The following is a description of a gene set: Human Gene Set: GOCC_FACIT_COLLAGEN_TRIMER studied in species Homo sapiens A collagen trimer that associates with collagen fibrils and consists of collagen monomers that contain two or more relatively short triple-helical domains connected by non-triple-helical sequences., and this is the list of marker genes: COL9A2, COL14A1, COL12A1, COL16A1, COL9A1, COL13A1, COL9A3 (NCBI Gene Id 1299)